Given this list of marker genes SC5D, POP1, SLF2, FLNB, BMPER, GALNS, COL2A1, GUSB, LBR, LHX3, VPS33A, EXTL3, GNPTAB, GBA1, RPS6KA3, MGAT2, MED12L, TRAPPC2, FBXO28, GLB1, ERLIN2, NPR2, NEPRO, AMN, ATG7 (NCBI Gene Id 105376952), FGFR3, CDH11, POLR3GL (NCBI Gene Id 84265), AMER1, SLC26A2, KIF22, CCN6, MAN2B1, NTRK1, here is a description of the gene set: Any structural abnormality of the lumbar vertebral column. Human Gene Set: HP_ABNORMAL_LUMBAR_SPINE_MORPHOLOGY Abnormal lumbar spine morphology species: Homo sapiens